Given this list of marker genes EGR2, HOXB1, NRP2, HOXB2, SEMA3A, PLXNA3, NRP1 (NCBI Gene Id 8829), PLXNA4, SEMA3F (semaphorin 3F), ADARB1, SIX1, here is a description of the gene set: Human Gene Set: GOBP_FACIAL_NERVE_MORPHOGENESIS species: Homo sapiens The process in which the anatomical structure of the facial nerve is generated and organized. This sensory and motor nerve supplies the muscles of facial expression and the expression and taste at the anterior two-thirds of the tongue. The principal branches are the superficial ophthalmic, buccal, palatine and hyomandibular. The main trunk synapses within pterygopalatine ganglion in the parotid gland and this ganglion then gives of nerve branches which supply the lacrimal gland and the mucous secreting glands of the nasal and oral cavities.